Given this list of marker genes GDNF, GJA1, CYP17A1, SERPINA5, DMRT1, HMGB2, B4GALNT1, GDI1, SOX8, KITLG, SF1, SLC12A2, DNAJA1, NR0B1, DHH, AR, CYP19A1, MAN2A2, BCL2L2, CDKN2C, ACVR2A, RBP4, HMGA1, INHA, CLDN11, SBF1, LHCGR, MAP7 (NCBI Gene Id 9053), here is a description of the gene set: Genes important for Sertoli, peritubular, Leydig and interstitial cells, based on mouse models with male reproductive defects. Human Gene Set: MATZUK_MALE_REPRODUCTION_SERTOLI studied in species Mus musculus from publication Matzuk MM, Lamb DJ (PMID 18989307) Reproduction is required for the survival of all mammalian species, and thousands of essential 'sex' genes are conserved through evolution. Basic research helps to define these genes and the mechanisms responsible for the development, function and regulation of the male and female reproductive systems. However, many infertile couples continue to be labeled with the diagnosis of idiopathic infertility or given descriptive diagnoses that do not provide a cause for their defect. For other individuals with a known etiology, effective cures are lacking, although their infertility is often bypassed with assisted reproductive technologies (ART), some accompanied by safety or ethical concerns. Certainly, progress in the field of reproduction has been realized in the twenty-first century with advances in the understanding of the regulation of fertility, with the production of over 400 mutant mouse models with a reproductive phenotype and with the promise of regenerative gonadal stem cells. Indeed, the past six years have witnessed a virtual explosion in the identification of gene mutations or polymorphisms that cause or are linked to human infertility. Translation of these findings to the clinic remains slow, however, as do new methods to diagnose and treat infertile couples. Additionally, new approaches to contraception remain elusive. Nevertheless, the basic and clinical advances in the understanding of the molecular controls of reproduction are impressive and will ultimately improve patient care.